Given this list of marker genes SLC11A1, SLC39A2, SLC11A2, SLC39A14, SLC39A8, SLC30A1, here is a description of the gene set: Human Gene Set: GOBP_CADMIUM_ION_TRANSMEMBRANE_TRANSPORT studied in species Homo sapiens A process in which a cadmium ion is transported from one side of a membrane to the other by means of some agent such as a transporter or pore.